The following is a description of a gene set: species: Homo sapiens Genes up-regulated in peripheral blood mononuclear cell 14d vs 0d in unknown after exposure to YF-Vax/Stamaril, time point 14D Human Gene Set: GAUCHER_PBMC_YF_VAX_STAMARIL_UNKNOWN_AGE_14DY_UP Correlates of immune-mediated protection to most viral and cancer vaccines are still unknown. This impedes the development of novel vaccines to incurable diseases such as HIV and cancer. In this study, we have used functional genomics and polychromatic flow cytometry to define the signature of the immune response to the yellow fever (YF) vaccine 17D (YF17D) in a cohort of 40 volunteers followed for up to 1 yr after vaccination. We show that immunization with YF17D leads to an integrated immune response that includes several effector arms of innate immunity, including complement, the inflammasome, and interferons, as well as adaptive immunity as shown by an early T cell response followed by a brisk and variable B cell response. Development of these responses is preceded, as demonstrated in three independent vaccination trials and in a novel in vitro system of primary immune responses (modular immune in vitro construct system), by the coordinated up-regulation of transcripts for specific transcription factors, including STAT1, IRF7, and ETS2, which are upstream of the different effector arms of the immune response. These results clearly show that the immune response to a strong vaccine is preceded by coordinated induction of master transcription factors that lead to the development of a broad, polyfunctional, and persistent immune response that integrates all effector cells of the immune system. from publication Gaucher D, Therrien R, Kettaf N, Angermann BR, Boucher G, Filali-Mouhim A, Moser JM, Mehta RS, Drake DR 3rd, Castro E, Akondy R, Rinfret A, Yassine-Diab B, Said EA, Chouikh Y, Cameron MJ, Clum R, Kelvin D, Somogyi R, Greller LD, Balderas RS, Wilkinson P, Pantaleo G, Tartaglia J, Haddad EK, Sékaly RP (PMID 19047440), and this is the list of marker genes: MZB1, CDCA5, SLC7A5, TNFRSF13B, PRDX4, ADA, MYO1F, TUBG1, CRELD2, TRIM26, DUSP5, CD38 (NCBI Gene Id 952), CD19, CCNB2, ACOT7, FKBP11, MANF, POU2AF1, FCRL5, IDH2, PPIB, SIL1, HSP90B1, FAM30A, TXNDC11, CDK12, TENT5C, SP140, MYDGF, UBE2C, SDF2L1, MCM4, XBP1, RTCB, GLDC, TXNDC5, MAGED1, CXCR3, MYL6B, TK1, SEC11C, CDC20, ITM2C, SRM, UHRF1, PHGDH, PDIA4, TNFRSF17, UBE2S, CENPM (centromere protein M), NUSAP1, COBLL1, STMN1, PTTG1, JCHAIN, NME1, CDCA7, SEL1L3